Given this list of marker genes KRAS, SLCO2A1, COL3A1, RUNX1, PERP, MAN2B1, NOTCH3, PDGFRB, MEN1, IDH1, KIF1A, SRSF2, HNRNPA1, BRAF, FGFR1, ELMO2, CHEK2, TNFRSF11A (NCBI Gene Id 8792), CBL, LMNA, GBA1, CTSK, BUB1B, BUB3, UROD, NOTCH2, CTSC, SQSTM1, CDKN2B, UROS, SLC29A3, VDR, RETREG1, BANF1, CCND1, ZBTB20, CDKN2C, IKBKG, MAP2K1, TET2, WNK1, ATL3, SCARB2, MMP2, SH3PXD2B, ASAH1, TRPV3, GNPTAB, GJB2, ZMPSTE24, HLA-DRB1, VCP, ASXL1, ELP1, HPGD, ANTXR2, SCN9A, NF1, MMP14, IL1RN, TP53, CTNNB1, CCR6, PTH1R, IRF5 (NCBI Gene Id 84729), BUB1, CAV1, RIGI, RB1, CDKN1B, MTX2, IDH2, MAFB, FLNA, IFIH1, TRIP13, NRAS, CDKN1A, CCN2, DDR2, APC, HNRNPA2B1, GATA1, MBTPS2, CEP57, PIGL, ATP7A, here is a description of the gene set: Human Gene Set: HP_OSTEOLYSIS Osteolysis refers to the destruction of bone through bone resorption with removal or loss of calcium. studied in species Homo sapiens Osteolysis